Given this list of marker genes Jun, Cd74, Junb, Hspa1a, Tsc22d3, here is a description of the gene set: Mouse Gene Set: CUI_T_CELL_CD4_M_CSF_RESPONSE_DN from publication Cui A, Huang T, Li S, Ma A, Pérez JL, Sander C, Keskin DB, Wu CJ, Fraenkel E, Hacohen N (PMID 38057668) Genes negatively differentially expressed in cell type: CD4+ T cell upon treatment with cytokine: M-CSF in mouse lymph nodes in vivo. Cytokines mediate cell-cell communication in the immune system and represent important therapeutic targets. A myriad of studies have highlighted their central role in immune function, yet we lack a global view of the cellular responses of each immune cell type to each cytokine. To address this gap, the authors created the Immune Dictionary, a compendium of single-cell transcriptomic profiles of more than 17 immune cell types in response to each of 86 cytokines (>1,400 cytokine-cell type combinations) in mouse lymph nodes in vivo. A cytokine-centric view of the dictionary revealed that most cytokines induce highly cell-type-specific responses. For example, the inflammatory cytokine interleukin-1β induces distinct gene programmes in almost every cell type. A cell-type-centric view of the dictionary identified more than 66 cytokine-driven cellular polarization states across immune cell types, including previously uncharacterized states such as an interleukin-18-induced polyfunctional natural killer cell state. studied in species Mus musculus